The following is a description of a gene set: Human Gene Set: GOBP_POSITIVE_REGULATION_OF_GAMMA_DELTA_T_CELL_ACTIVATION Any process that activates or increases the frequency, rate or extent of gamma-delta T cell activation. studied in species Homo sapiens, and this is the list of marker genes: STAT5A, NOD2, PTPRC (NCBI Gene Id 5788), NCKAP1L, LEF1, STAT5B, SOX4, LCK, SOX13, SYK, LILRB1